The following is a description of a gene set: species: Homo sapiens Human Gene Set: chr21q21, and this is the list of marker genes: LINC01692, RAD23BP3, C21orf91, GAPDHP14, RN7SKP147 (NCBI Gene Id 106480879), RPS26P5, RN7SKP236, ATP5PF, ADAMTS1, RNU1-139P, RWDD2B, MIR548XHG (MIR548X host gene), RPL13AP7, USP25, FDX1P2, RNU4-45P, NCAM2, RPL23P2, MIR155, RBPMSLP, TUBAP1, RNU6-772P, MAPK6P2, RNU1-98P, APP, RNA5SP489, C21orf91-OT1, MRPL39, MSANTD2P1, LINC01549, LINC00113, MIR4759, LINC02920, PPIAP22, THUMPD1P1, RPL39P40, EIF4A1P1, RNU6-1326P, RPL37P4, NEK4P1, RNU6-123P, LINC02573 (NCBI Gene Id 111216285), VDAC2P1, SNORD74B, ZNF299P, ADAMTS5, ENSG00000229962, MIR99AHG, BACH1-IT3, BTG3, LINC00320, JAM2, LINC00158, BACH1-AS1, TMPRSS15, ASMER1, RNU6-113P, NCSTNP1, RNU2-55P, ENSG00000229425, ENSG00000212479, LINC01697, LINC01687, MIR6130, C1QBPP1, ENSG00000288094, FDPSP6, CHODL-AS1, PPIAP1, GPX1P2, LINC01689, BACH1, RPS3AP1, RNU6-426P, CCT8, RPL37P3, LINC00308, MIR99A, MIR155HG, RPL12P9, CLDN17, ENSG00000227716, RN7SL163P, CYCSP42, LINC01695, SLC6A6P1, LINC01425 (NCBI Gene Id 101927821), MIR548X, CXADR, MIR125B2, CHODL, RNU6-926P, KRT18P2, APP-DT, GRIK1, HSPD1P7, NIPA2P3, EEF1A1P1, ENSG00000288578, USP16, BTF3L4P1 (basic transcription factor 3 like 4 pseudogene 1), BACH1-IT2, LINC00314, LINC00317, NRIP1, GRIK1-AS1, CYYR1-AS1, MAP3K7CL, LINC01673, SREK1IP1P1, CYYR1, LLPHP2, MIRLET7C, N6AMT1, RNGTTP1, BTG3-AS1, LINC01684, ENSG00000306081 (NCBI Gene Id 105372766), RPL10P1, LINC00161, LTN1, GABPA (NCBI Gene Id 2551), LINC00189, LINC01683